Given this list of marker genes Srl, Casq1, Tmem38a, Akap6, Art1, Itpr2, Fkbp1b, Rtn2, Slc30a7, Jph2, Syne2, Cherp, Nos1ap (nitric oxide synthase 1 (neuronal) adaptor protein), Stim1, Klhl41, Sln, Camk2b, Atp2a3, Pln, Jph1 (junctophilin 1), Strit1 (small transmembrane regulator of ion transport 1), Nos1, Reep5, Camk2d, Sri (NCBI Gene Id 73025), Camk2g, Ryr1, Ryr2, Tmem109, Atp2a2, Asph, Jsrp1, Trdn, Hrc, Fkbp1a, Mrln, Dhrs7c, Atp2a1, Ryr3, Dmpk, here is a description of the gene set: studied in species Mus musculus The lipid bilayer surrounding the sarcoplasmic reticulum. Mouse Gene Set: GOCC_SARCOPLASMIC_RETICULUM_MEMBRANE